Given this list of marker genes POMK (NCBI Gene Id 84197), POMT2, FKRP, GMPPB (NCBI Gene Id 29925), POMGNT1, POMT1, here is a description of the gene set: Fusion of the cerebellar hemispheres species: Homo sapiens Human Gene Set: HP_FUSION_OF_THE_CEREBELLAR_HEMISPHERES